The following is a description of a gene set: part of: Diseases associated with N-glycosylation of proteins Dol-P-Man:Man(7)GlcNAc(2)-PP-Dol alpha-1,6-mannosyltransferase (ALG12) normally tranfers the 8th mannose moiety to the lipid-linked oligosaccharide (LLO aka N-glycan precursor) which is required for subsequent N-glycosylation of proteins. Defects in ALG12 are associated with congenital disorder of glycosylation 1g (ALG12-CDG, CDG1g; MIM:607143), a multisystem disorder caused by a defect in glycoprotein biosynthesis and characterised by under-glycosylated serum glycoproteins. CDG type 1 diseases result in a wide variety of clinical features, such as defects in the nervous system development, psychomotor retardation, dysmorphic features, hypotonia, coagulation disorders, and immunodeficiency. Reactome Pathway: Defective ALG12 causes CDG-1g studied in species Homo sapiens, and this is the list of marker genes: ALG12